Given this list of marker genes Ndst4, Ext2, Xylt2, Angpt1, Slc10a7, Ext1, Glce, Ndst1, Ndst2, Ndst3, here is a description of the gene set: Mouse Gene Set: GOBP_HEPARIN_PROTEOGLYCAN_BIOSYNTHETIC_PROCESS The chemical reactions and pathways resulting in the formation of heparin proteoglycans, which consist of a core protein linked to a heparin glycosaminoglycan. The heparin chain is composed of the repeating disaccharide unit beta-(1,4)-N-acetyl-D-glucosamine-alpha-(1,4)-hexuronic acid, the former being either sulfated or deacetylated on its amino group as well as sulfated on one of its hydroxyl groups, and the latter being a mixture of sulfated and nonsulfated D-glucuronic and L-iduronic acids. Heparin is similar to heparan sulfate but it contains more N-sulfate and O-sulfate groups. Heparin chains are covalently linked to serine/threonine residues (O-linked) of the core protein via a tetrasaccharide linker sequence (xylose-galactose-galactose-glucuronate). species: Mus musculus